The following is a description of a gene set: Human Gene Set: GSE7348_LPS_VS_TOLERIZED_AND_LPS_STIM_MACROPHAGE_DN species: Homo sapiens The inflammatory response initiated by microbial products signaling through Toll-like receptors (TLRs) of the innate immune system is essential for host defense against infection. Because inflammation can be harmful to host tissues, the innate response is highly regulated. Negative regulation of TLR4, the receptor for bacterial lipopolysaccharide (LPS), results in LPS tolerance, defined as hyporesponsiveness to repeated stimulation with LPS. LPS tolerance is thought to protect the host from excessive inflammation by turning off TLR4 signal, which then shuts down TLR-induced genes. However, TLR signaling induces hundreds of genes with very different functions. We reasoned that genes with different functions should have different requirements for regulation. Specifically, genes encoding proinflammatory mediators should be transiently inactivated to limit tissue damage, while genes encoding antimicrobial effectors, which directly target pathogens, should remain inducible in tolerant cells to protect the host from infection. Using an in vitro system of LPS tolerance in macrophages, here we show that TLR-induced genes may indeed be divided into two distinct categories based on their functions and regulatory requirements. Further, we show these distinct groups are regulated by gene-specific, and not signal-specific mechanisms. from publication Foster SL, Hargreaves DC, Medzhitov R (PMID 17538624) Genes down-regulated in macrophages in response to LPS: naïve versus tolerant., and this is the list of marker genes: ADAMTS6, CUTC, TOR1AIP2, BMP10, CTRL, IL18RAP, MTTP, PHC2, LYSMD2, MYCBP2, COBLL1, CCL5, RGL1, RARS1, KEAP1, PDGFD, LLGL1, ELOA, STXBP1, LYN, ELF1, APBA1, JPT1 (Jupiter microtubule associated homolog 1), SOS1, PHETA2 (NCBI Gene Id 150368), IQCC, RNF214, PHLDB2, NXF2, PLN, HERPUD2, CYLD, SLC37A3, ASAH2, NSMAF, IL23R, WARS1, MFSD9, SESN3, RAF1, SVBP, HMBOX1, CAPN5, ATG16L1, LMO2, RAB21, CACNB2, CASP2, CDYL2, G3BP2, ITPR1, STARD8, MLYCD (malonyl-CoA decarboxylase), ANGPT1, CENPJ, IL18 (NCBI Gene Id 3606), GCA, TTC21A, PPP1R13B, GOLGA3, XKR8, BCKDHB, INPP5K, ARMC8, IL12RB1 (interleukin 12 receptor subunit beta 1), NMRK2, PIWIL4, AKT3 (AKT serine/threonine kinase 3), TTC9B, FOXL2, HAP1, OGFRL1, P2RY13, PLEKHA2, TMUB2, STC1, FBXW7, TTC9C, AIDA, ASB1, HCAR2 (hydroxycarboxylic acid receptor 2), PRM1, ITGA4, CCDC27, KAT2B, RAB3IP, FBXO47, PHACTR4, CCDC6, PSMB8, ARL4A, HSH2D, SYCP2L, MIR342, TLR3, ZEB1, SRGAP2, PARP8, ABHD16A, MLKL, ARID3B, UBE2L6, ASB13, PHF20L1, PDK3, UACA, NOS2, TENT2, CALB2, TNFRSF14, CNEP1R1, RNF34, WDR44, TUT7, MED12L, PARP3, SNTB1, TMBIM4, TBC1D22B, PRKCQ, PPP1R12A, SGCB, RUNDC1, ACER3, PHF21A, ENG, DYNC1H1, CD2AP, FOXRED1, ARHGAP25, RASGRP1, DUSP10, SPATS2L, EXT1, RNF135, NUB1, HDAC1, DBNL, CRYBG1, IL7, UCN, CLK3, SERTAD3, CYSLTR2, CPEB3, EHD4, MAFB, FAM171B (family with sequence similarity 171 member B), PLA2R1, GNB4, TNFSF8, AIM2, RNPEPL1, IKZF2, PNMA1, CLIC5, CASP8, RBM41, STX7, IFT22, GTPBP2, TPST2, NUDT13, ALDH1L1, LPAR6, SIPA1L1 (NCBI Gene Id 283567), ATM, DYNC1I2, BICRAL, LIPE, OAS3, MINPP1, HERC1, HEG1